Given this list of marker genes CCL20, MX1, CMPK2, SERPINE1, SAMHD1, SPAG9, CCL2, FTH1, MX2, LIPG, PARP14, RHOB, CXCL11, ITGAV, HLA-A, RIPK2, OAS1, LAMB3, CCL11, CASP1, DDX60, HLA-B, BST2, MMP10, DRAM1, TNIP1, CXCL6, CCL8, CTHRC1 (NCBI Gene Id 115908), TNFAIP2, SOD2, SLC15A3, GBP1, HLA-E, NFKBIA, NCEH1, CSF1 (NCBI Gene Id 1435), OAS2, ICOSLG, PDGFRL, UBD (ubiquitin D), RAC3, IL7R, ACKR3, VCAM1, INHBA, IFIT1, LGALS3BP, C1S, DNAJA1, HSD17B11, MMP3, ANO9, SAT1, CX3CL1, TNFAIP3, SSPN, C1QTNF1, LGALS9, ICAM1, IFI44L, SAMD9L, CXCL2, IFIH1, HLA-C, SMAD3, OAS3, BPGM, TAPBP, CXCL3, RABL3, BIRC3, TLR2, DENND11, CXCL10, ATP13A3, PLA1A, OXR1, CCL7, APOL3, CXCL8, APOL1, IL32, here is a description of the gene set: species: Homo sapiens To investigate the potential molecular mediators of tissue-specific recruitment, we explored the influence of different cytokine challenges on gene expression regulation in five primary endothelial cells (ECs), representing two different phenotypes: iliac artery and aortic (macrovascular); lung, colon and dermal (microvascular). We challenged ECs with cytokines that elicit different patterns of inflammatory and immune responses in immune cells: tumor necrosis factor (TNF-alpha), interferon-gamma (IFN-gamma) or interleukin-4 (IL-4), and used microarrays containing approximately 40,000 unique cDNAs, to assess changes in differential gene expression relative to untreated cells. Five hundred and sixty three sequences changed by at least 2.5 fold in one or more of the 15 possible EC /cytokine combinations. The list included highly regulated adhesion molecules, chemokines, cytokines, metalloproteases, and IFN-gamma-induced genes. Overall, IFN-gamma caused the largest number of gene expression changes and its profile was least correlated with IL-4. In addition to clusters that were predominantly EC/cytokine specific, we also observed several clusters that were regulated by more than one cytokine across several ECs. Furthermore, we identified genes that were reciprocally expressed in response to different cytokines that could serve as markers of inflammatory and immune expression. These results confirm the importance of microenvironment in primary ECs that could have important applications in developing targeted therapies for vascular diseases. from publication Sana TR, Janatpour MJ, Sathe M, McEvoy LM, McClanahan TK (PMID 15749026) Human Gene Set: SANA_TNF_SIGNALING_UP Genes up-regulated in five primary endothelial cell types (lung, aortic, iliac, dermal, and colon) by TNF.